The following is a description of a gene set: species: Homo sapiens Human Gene Set: WP_PYRIMIDINE_METABOLISM_AND_RELATED_DISEASES Pyrimidine metabolism and related diseases, and this is the list of marker genes: ABAT (4-aminobutyrate aminotransferase), RRM2, ALDH6A1, DPYD, RRM2B, UPB1, TYMP, AGXT2, GLS2, NT5C, CAD (NCBI Gene Id 790), CPS1, DHODH, TK2, TYMS, UMPS, NT5C3A, OTC, DPYS, RRM1